The following is a description of a gene set: Human Gene Set: GOBP_POSITIVE_REGULATION_OF_MOLECULAR_FUNCTION Any process that activates or increases the rate or extent of a molecular function, an elemental biological activity occurring at the molecular level, such as catalysis or binding. species: Homo sapiens, and this is the list of marker genes: BAMBI, PIBF1, RAPGEF6 (Rap guanine nucleotide exchange factor 6, NCBI Gene Id 51735), STAC, RGS6, PILRB, TSC1, TRIM37, S100A9, STIM1, ODAM, TRIM27, TRAF5, CDC14B, LARS1 (leucyl-tRNA synthetase 1), ADAM17, NCBP1, SIRT1, HLA-DRB1, P2RY11, ALK, RASGRP1, TERF2IP, PIM1, FGFR4, KIT, HES1, IL26, NEUROD2, STOX1, IL18R1, RPS3, RNF31, PRKD1, IL18, MAP3K7, SKP1, PRKD2, MID2, ARID5B, AKTIP, PRKCD, FGFR1, TMIGD3, PPIA, AKT1, SPHK1, ADD2, NEUROG2, S100A10, IGF1, TBC1D7, ETAA1, FLOT1, CD4, THY1, PRKCQ, JAK2, PIH1D1, PRDX3, VCP, DNAJB2, SNX13, ADORA3, SIRT3, CDT1, RCN3, BDNF, DVL3, MAP3K10, RACK1, EP300, RBCK1, DOCK9, UBE2S, PHACTR4, STX4, SRGAP2, INS, SPDYA, BCR (BCR activator of RhoGEF and GTPase), RPS2, MAP3K4, IL10, DRD5, DBI, BMP2, ABR, TRIM14, AIM2, ZC4H2, MTDH, RALBP1, FXN, MAPK8, TOM1L1, STIM2, RGP1, EGF, TLR4, RB1, MMP9, RAB3GAP1, AVPR2, ALS2, TSSK4, STAC3, TMSB4X, TESC, ARHGAP42, SKI, ADCY1, IFNG, GABARAPL2, WRN, BMI1, LRRC55, HAND2, ZC3H15, CASQ1, ARHGEF5, RNF25, PSMD10 (proteasome 26S subunit, non-ATPase 10), RASSF2, TCF3, SCRIB, CARD10, POU4F1, PLK1, DDIT3, DAZAP2, MT3, CIB1, PSAP, CD74, CAB39, EVI5L, MAPK14, TLR2, LRRC26, GPSM1, TENM1, GAL, PTK2, PINX1 (PIN2 (TERF1) interacting telomerase inhibitor 1), VMP1, ARHGEF2, MAP3K13, CAMK2A, DYNAP, SRCIN1, ESR2, GRN, IL24, MAP2K3, PLSCR1, ECT2, PDCD10, PIK3CG (phosphatidylinositol-4,5-bisphosphate 3-kinase catalytic subunit gamma), EIF4G1, TOR1AIP2, TRIM26, WNK2, CRIPTO, BTRC, GCH1, MAGEA2B, UBE2N, APC2, JPH2, CDC20, ADCYAP1, TNNT2, PIK3R5, CTSS, ACTN2 (actinin alpha 2, NCBI Gene Id 88), CORO1C, XRCC6, F2RL1 (F2R like trypsin receptor 1), DHX33, CAP1, TAB2, CHUK, DOK7, NOD2, AGER, SRC (NCBI Gene Id 6714), NIBAN2, TRIM15, SETMAR, IRGM, CRNN (NCBI Gene Id 51413), XRCC5, FOXA1, AGRN, EPHA5, ZFP91, RALB, TRAF2, ABI1, MAGEC2, RAPGEF3, MYL3, TRIM25, PLAUR, MMD, SGSM2, NLRP3, CRHR1, CARD14 (NCBI Gene Id 79092), RAPGEF2 (Rap guanine nucleotide exchange factor 2), DPH3, ACR, GTF2B, PHB2, DDR2, EZH2, RHOG, USP17L2, RPS6KA5, CAMK1D, RGS16, IRAK1, ABL1, MST1R, IDE, CREB3, NCOA3, GBA3, GAS6, HTT, GIPR, FGF10, UNC119, SUMO4, EDN1, MAGEA2, EVI5, AHSA1, DIPK2A, ZNF622, PLAAT4, GSK3B, ARRDC3, RFK, WNK3, RGN, ARHGEF16, NEK10, STK11, HNRNPU, TPX2 (TPX2 microtubule nucleation factor), MRNIP, RFC2, LGALS9, CALCA, PARP9, NEUROD1, HMGB1, EDF1, TNFRSF10A, NDEL1, NVL, DSTYK, HMGA2, ADORA2B, NEUROG1, CLOCK (NCBI Gene Id 9575), TNFSF15, CR1, CEBPG, CARD9, NET1, EPB41, DOCK8, CLU, RPL11, RHOC, BCAR3, FGF23, GNB5, RASGRP2, CHTF18, MAPK3, EDN2, RIC1, FGF18, ARHGAP11A, NEDD9, TRIM38, TNFRSF10B, B3GAT3, MAP2K2, ATF2, TRIM31, SGK1, ZNF16 (NCBI Gene Id 7564), CACNA1C, NRG1, RNF220, MED25, PTK2B, MYL4, HAP1, LRRC38, RIPOR1, ARHGEF7, FGFR3, CHP1, SEMG1, ITGA6, SASH1, HSPA1B, TANK, ANXA3, TRAF6, DDRGK1, RGS1, PLXNB1, RIPK3, RARA, MBP, PRTN3, PRELID1, PRKCZ, SNX9, RIPK4, PRKCH, CRTC2, CHI3L1, WNT5A, TGM2, NMD3 (NCBI Gene Id 51068), CSF1R, TNNT3, USP6NL, ITGB1, TRIM8, TIGAR (NCBI Gene Id 57199), RTKN2, CIMAP3, S100A12, DOCK10, RIPK1, DNAJC9, USP9X, PDGFB, PSENEN, NLRC4, CFTR, TWIST1, FBN1 (fibrillin 1), NTRK1, XRCC4, ACTN4, S100A8, RAP1A, PFN2, TRIM22, PIK3R6, STIMATE, RAB7B, TLR3, SEMA4D, TCAF1, SYDE1, GPRC5B, BCAS3, PTPN1 (NCBI Gene Id 5770), ARRDC4, RALGAPB, RGS7, CD40LG, TBC1D30, LAT, TIAM1, POLG2, CHP2, TRIM5, MID1IP1, RFC3, TRIM13, GMNN, PRSS22, EIF2AK2, ROR1, FOXC1, AGAP2, ADIPOQ, LIMS1, COPS8, MAP2K1, IL19, MAP3K11, SYNGR3, TRIM62, LEP, TXN, CHTOP, SSBP1, COPS5, TLR6, DSCC1, TOR1AIP1, CEMIP, DHX9, TRIM34, JTB, TRAF4, RAB11FIP2, TNF, RTN4R, RALGAPA2, FER, DIRAS2, ERBB2, GPLD1, FZR1, ARHGAP11B, RGS10, CLN5, NIPSNAP2, USP33, SIPA1L1, SYT14P1, PNLIP, GUCA1A, TRIM21, GLP1R (glucagon like peptide 1 receptor), PDGFRB, EIF3E, EPHA4, TPD52L1, FANK1, ESR1, SGSM3, CRACR2A, SNCA, TRPC6, SEMG2, DNAJB11, DDX11, RSU1, SH3BP1 (SH3 domain binding protein 1), NF1, TBC1D2, TRAF1, MTMR9, BMP4, FGFR2, LILRA5, ZBTB7A, CRTC1, PRKCI, CHTF8, VSIR, TCIM, TNFSF18 (TNF superfamily member 18), CENPE, CLSPN, ERC1 (ELKS/RAB6-interacting/CAST family member 1), TFDP1, RANGAP1 (Ran GTPase activating protein 1), EREG, PABPN1, ADD1, IL18RAP, SIRT2, SRF, MAP3K5, POU4F2, CCDC125, BTK, LRRC52, EEF1A2, FGF2, CARD16, DRD4, RELA, RHOA (NCBI Gene Id 387), FGF13, ARAP1, NPM1, TAOK3, LCP2, DNAJC24, IL20, TRIM52, EPHA2, SYDE2, CASS4, ASAP3, ANGPT1, EDNRA, SERPINB3, UBE2C, PFN1, ERN1, FLT1, ATPSCKMT, HSPA1A, FLT3, GATA3, PRLR (NCBI Gene Id 5618), MET, SCN1B, RAPGEF1, ITGB1BP1, MMUT, CACUL1, PYCARD, SYAP1, RGS8, MTSS2, TRIM6, RFC4, COX17, MTPN, NPR3, CCNY, CDKN1A, CAP2, PTPRC, GALR2, KIF14, AZIN2, MAP4K2, IKBKG, LMO4, RFC5, ZIC2, DOCK11, ATP2A1, TBC1D20, CARD11, PCNA, STRADA, NHEJ1, ELANE, RAN, STRADB, NME1 (NME/NM23 nucleoside diphosphate kinase 1), H1-0, DIRAS1, PLIN5, RAP1GAP, LTF, KDM4D, ASPH (NCBI Gene Id 56921), RPS6KA4, IKBKB, PIP5K1A, NOD1, MYD88, ADCY8, PLA2G5, GNAS, SGK2, ORAI1, RHEBL1, STAC2 (SH3 and cysteine rich domain 2), PPARG, BCL10, CACNA1D, DTX3L, DACT1, FGF1, MMD2, CDH3, EIF3C, CACNB3, STING1, RIPOR2, RALGAPA1, TERT, GUCA1ANB-GUCA1A, PYHIN1, CAMK1, CCDC88A, TRIM32, SNX18, STMN1